The following is a description of a gene set: Mouse Gene Set: GOMF_OXIDATIVE_PHOSPHORYLATION_UNCOUPLER_ACTIVITY Enables the transfer of protons from mitochondrial intermembrane space into mitochondrial matrix, dissipating the proton gradient across the mitochondrial inner membrane established by the electron transport chain during the oxidative phosphorylation (proton leak). Proton leak uncouples the processes of electron transport/proton generation and ATP synthesis. studied in species Mus musculus, and this is the list of marker genes: Ucp2 (NCBI Gene Id 22228, uncoupling protein 2 (mitochondrial, proton carrier)), Ucp3, Slc25a5, Ucp1, Slc25a4